Given this list of marker genes FN1 (NCBI Gene Id 2335), ITGB1, VEGFC, TNC, PAOX, RAC1, VEGFA, KCNJ15, ITGA9, BCAR1, ADAM12, SPP1, NOS2, ADAM8, VCAM1, VEGFD, CSF2, SAT1, ADAM15, PXN, TGM2, CSF2RA, ADAM2, F13A1, SRC, here is a description of the gene set: from publication Schaefer CF, Anthony K, Krupa S, Buchoff J, Day M, Hannay T, Buetow KH (PMID 18832364) Alpha9 beta1 integrin signaling events studied in species Homo sapiens Human Gene Set: PID_INTEGRIN_A9B1_PATHWAY